The following is a description of a gene set: studied in species Homo sapiens Human Gene Set: GOBP_CELLULAR_RESPONSE_TO_NITROGEN_LEVELS Any process that results in a change in state or activity of a cell (in terms of movement, secretion, enzyme production, gene expression, etc.) as a result of a stimulus reflecting the presence, absence, or concentration of inorganic nitrogen., and this is the list of marker genes: GABARAP, GABARAPL2, ATG5, MAP1LC3B, GABARAPL3, ATG7, BECN2, MAP1LC3A, MAP1LC3C, GABARAPL1, MAP1LC3B2, BECN1